Given this list of marker genes Adcy10, E2f3, Pdcd4, Il12b, Grp, Il12a, Atf4, Pparg, Foxo1, Bag1, Cdkn2a, Stub1, Mfn2, Ifng, Rbm10 (NCBI Gene Id 260306), Stk4, Arrb1, Sod2, here is a description of the gene set: Mouse Gene Set: GOBP_POSITIVE_REGULATION_OF_SMOOTH_MUSCLE_CELL_APOPTOTIC_PROCESS Any process that activates or increases the frequency, rate, or extent of smooth muscle cell apoptotic process. studied in species Mus musculus